The following is a description of a gene set: from publication Feuerer M, Herrero L, Cipolletta D, Naaz A, Wong J, Nayer A, Lee J, Goldfine AB, Benoist C, Shoelson S, Mathis D (PMID 19633656) Human Gene Set: GSE7852_LN_VS_FAT_TREG_DN Comparisons of global gene-expression profiles revealed a greater distinction between CD4+ Treg cells and CD4+ conventional (Tconv) T cells residing in abdominal (epidydimal) fat versus in more standard locations such as the spleen, thymus and LN. species: Homo sapiens Genes down-regulated in comparison of lymph node regulatory T cells versus fat tissue regulatory T cells., and this is the list of marker genes: PLEC, FAM135A, YPEL2, TOB1, MT1E, ELF1 (E74 like ETS transcription factor 1), WDTC1, ELL2, LTB4R, CRIP2, TSC22D2, DRAM1, EYA2, DIAPH1, CXCR6, PCYT1A, ALCAM, PLCL2, RGCC, IRF6, INSIG1, GSN, DNASE1L1, FLNB, TBX15, MFSD6, MGAT4B, RGS5, ADIPOR2, CDH17, RHOBTB1, ECHDC2, HOPX, PCDH19, VPS8, KIFAP3, VPS37B, IFNA1, INPPL1, TPP2, EPM2A, CHST1, CLTC, DNAJB4, FZD4, AHNAK, CAVIN3, WSB1 (NCBI Gene Id 26118), AGPAT4, ARL13B, ARHGAP31, SLC41A2, RRAD, GALC, MTARC1, COQ8A, ZNF503, PER1, ARL14EP (ADP ribosylation factor like GTPase 14 effector protein), ARHGAP21, HBB, SQLE, CCR4, SELENOM, CENPL, PHLDA1, IQGAP1, PCDH18, ETS2, MITF, MID1IP1, GK, RABGEF1, KCTD16, MEGF9, SYNE1, COBLL1, CIB4, ANXA4 (NCBI Gene Id 307), BLTP3B, DLG5, RALGDS, ACSS2, RAB20, ZC3HAV1 (zinc finger CCCH-type containing, antiviral 1), DUSP3, NR4A3, UBALD2, ID2, GALNT2, MAFF, CAPN2, DENND4A, IL10RA, ITPRIPL2, IER5L, TBC1D19, SDCBP2, ACOD1, GRAMD1C, PRKAR2B, HLF, ABLIM3, ELOVL6, EFCAB6, H3C4, TGIF1, PKD2, DNAJB9, RBPJ, RAMP1, GNB1, IER3, LHFPL6, NDEL1, PBX3, ATP2A2, FAM107B, ARHGAP23, CARHSP1, ELOVL5, BEX2, IL12RB1, FBXO33, OSBPL3, SQSTM1, PLEKHA7, ZC3H12A, KIF23, RELL1 (RELT like 1), FEM1C, RASGRF1, SLC52A3, GLRX, COL16A1, ITGA1, SAMD14, MAPKAPK3, CCR2, SGMS2 (NCBI Gene Id 166929), DCTN1, HS6ST2, WDSUB1, NADK, AGPAT2, SAMSN1, CSGALNACT1, L1CAM, MYO3A, NINJ1, TMTC2, SYNE2, BAMBI, GCH1, MT2A, CSTB, RBP7, VEZF1, SMAD3, FZD5, RAP1GAP2, NCEH1, RHOB, ADGRG3, EMB, JDP2, MAGI1, TMEM64, IL18RAP, TPD52, HOXD9, CXCL10, MLF1, IMPA2, DUSP1, GALNT1, SHROOM4, TMBIM1, SLCO3A1, CHMP4C, TKTL1, ARNT2, PHKA1, TNFSF9, IRF5, MAFG, CMTM8, GLS2, SRGN, SAP30, BRD2, CD99, RNF125, RAPGEF2, IDI1, GRK5, PARD3B, TGIF2, SLC35E2B, SOX6